The following is a description of a gene set: studied in species Homo sapiens Any process that modulates the frequency, rate or extent of telomere maintenance in response to DNA damage. Human Gene Set: GOBP_REGULATION_OF_TELOMERE_MAINTENANCE_IN_RESPONSE_TO_DNA_DAMAGE, and this is the list of marker genes: ACTR5, ACTR8, UCHL5, ERCC1, INO80, MCRS1, INO80C, XRCC1, RUVBL1, ACTL6A, TFPT (TCF3 fusion partner), INO80B, INO80D, INO80E, RTEL1 (regulator of telomere elongation helicase 1), ERCC4, NFRKB, YY1, RUVBL2